Given this list of marker genes GPAM, ZBTB18, VIM, FERMT2, VDAC2, LIN9, DCAF10, AMMECR1 (AMMECR nuclear protein 1), LZTS3, ARHGAP6, TMPO, SCN5A, MAN2A1, RELN, FEM1C, CLIP1, VCF2, BEST2, ARL5B, SFSWAP (splicing factor SWAP), DESI2, ADAMTS1, PDIK1L, TENT4B, PCGF3, DTX4, NFIB, FOXP4 (forkhead box P4), SULF2, EVC, PLAU, MAP3K7CL, NFIX, MINDY2, RB1CC1, AGO4, CCND3, TANC1, PPARD, ST6GALNAC4, SEZ6L2, SCRN1, ABI1, PDAP1, SRSF6, YIPF5, RASSF8, KLHDC10, C2CD2L, RARA, DUSP16, ACVR2B, AFAP1L1, RNF38, TBL1X, PDZD8, APPBP2, KLHL18, TBC1D4, RNF126, KMT5B, RIMS2, SPRN, DEK, ZER1, FRMD5, STOX2, VEZF1, ALDH6A1, L3MBTL3, PTPN4, PHF21A, EID1 (NCBI Gene Id 27110), NEUROD1, DNAJB11, SERTM1, SPOCK3, SERTAD4, SGIP1, PPIP5K1, SH2B3, CASTOR2 (cytosolic arginine sensor for mTORC1 subunit 2), ATP11C, CLVS1, KLF12, BAZ1B, BLZF1, HECTD2, EFNB3, BAZ2B, CREBZF, PAN3, MAST4, TSTD3, GNG2, KLF11, RPRD1B, MICAL3, here is a description of the gene set: Genes predicted to be targets of miRBase v22 microRNA hsa-miR-6131 in miRDB v6.0 with MirTarget v4 prediction scores > 80 (high confidence targets). Human Gene Set: MIR6131 from publication Chen Y, Wang X (PMID 31504780) studied in species Homo sapiens